Given this list of marker genes Rpl18a, H1f5, Lcn2, Atp5f1b (ATP synthase F1 subunit beta), Chil3, Rpl41, Smc6, Ncapd3, Eef1a1, Hp (NCBI Gene Id 15439), Nars1, Rps3a1, Rpl23, Ezh2, Rps2, Rps3, Prxl2a, Rpl7, Eif3e, Erdr1, Rpl29, Rpl11, Pclaf, Cyba, Rpl27a, Luc7l3, Rpl14, Top2a, Rps15a, S100a8, Rps6, Hsp90ab1, Calr, Rpsa, Retnlg, Ifitm2, Cox6b2, Calm1 (NCBI Gene Id 12313), Rplp0, Eef1b2, Cdk1 (NCBI Gene Id 12534), Rps11, Rps24, Rps19, Pbrm1, Wfdc21, Son, Psma7, Pglyrp1, Eif2s2, Rpl13a, Rpl27, Srsf11, Rbm39, Psmb2, Prpf4b, Ppig, Sh3bgrl3, H1f4, S100a6, Apol11b, Tfrc, Fcer1g, Srrm1, Rpl32, Bub3, Asns, Gadd45gip1, Tmsb4x, Rsrp1, Tpr, Mthfd2, Smc1a, Rpl13, Rpl36a, S100a9, Rpl38, S100a11, Ldha, H2ac8, Rpl36, Rps25, Ppia, Tmem234, Hint1, Snrpa1 (small nuclear ribonucleoprotein polypeptide A'), Ifitm6, Tspo, Rps18, Npm1, Rpl5, Aldoa, Eif5, Cldn13, Ccdc34, Arhgdib, Rpl22l1, Rpl12, Atf4, Park7, Ube2c, Gapdh, Slc3a2, Hsp90aa1, Pim1 (proviral integration site 1), Zbtb7a, Ncl, Rps5, Rpl36al, Rps9, Cd52, Kpna2, Eef2, Jchain, Rexo2, Rpl24, Rpl10a, Cycs, Crip1, Clic1, Prdx4, Tyrobp, Rps16, H2-D1, Rpl15, Baz1b, Eif3i, Camp, Rack1, Rps14, Smc4, Rps27a, Lyz2, Rpl4, Prc1, Eif4ebp1, Eif3c, Rps13, Rpl35, Naca, Rps17 (NCBI Gene Id 20068), Crip2, Med13l, Rpl7a, Tmsb10, Rpl37, Pgp, Smc2 (NCBI Gene Id 67947), Rpl8, Rps7, Rps15, Rps10, Rpl17, Esco2, Rpl19, Gstm5, Abcg2, Eef1g, Knl1, Nme1, Rps28, Rpl6, Eif5b, Rpl18, Fau, Rpl9, Cenpe, Rps23, Fbxo5, Slpi, Ltf, Dbi, Arl6ip1, Prdx1, H1f3, Rps12, Rpl3, Rpl10, Rpl37a, Rplp1, Cox4i1, Ngp, Pafah1b1, Rps20, Malat1 (metastasis associated lung adenocarcinoma transcript 1 (non-coding RNA)), Rps4x, Pkm, Rps8, Cenpf, Car1, here is a description of the gene set: species: Mus musculus Mouse Gene Set: TABULA_MURIS_SENIS_MARROW_ERYTHROBLAST_AGEING from publication Tabula Muris Consortium (PMID 32669714)